Given this list of marker genes SNAI2, ATXN1L, MIR320B2, SOX17, RNF43, PTCH1 (patched 1), OVOL1, CD109, HMGB2, PIM1, HNRNPU, ZFP36L1, YAP1, TGFBR1, FGF8, MIR221, NF2, MIR320D1, NF1, ARIH2, AGO3, OVOL2, RUNX1, HMX2, VEGFC, MIR320D2, DSG2 (NCBI Gene Id 1829), IFT80, SHOX2, NFIB, NANOG, L3MBTL2, ETV6, PBX1, HOXB4, YTHDF2, CD34, ACE, RUNX2, SFRP2, FGF10, FGF4, CEBPA, KDM1A, PRRX1 (paired related homeobox 1), SHB, WNT10B, PDCD2, SIRT6, IRF6, MIR222, SOX18, WNT11, EIF2AK2, TP63, NR2E1, CITED1, CTNNB1, NKAP, BRCA2, NES, FGF2, RBPJ, MIR16-1, MIR93, RARG, MIR320C2, HOXA3, FBLN1, CCNE1, EPCAM, MIR320A, FGFR1, WNT1, WNT7B, WNT3, TP53, KDR, KAT7, KDF1, FGF9, TGFB1, XRCC5, BYSL (bystin like), GBA1, AXIN2, FERMT1, ELL3, LIG4, MIR320E, CTC1, MIR29B1, TGFBR2, SIX2 (NCBI Gene Id 10736), KITLG, THPO, MIR320C1, GJA1, GLI3, ZNRF3, TRIM71, TERT, TSC22D1 (TSC22 domain family member 1), WNT2B, DGCR8, BABAM1, MIR320B1, SFN, ANG, SHH, RARB, LTBP3, YJEFN3, PTPRC, WNT5A, NOTCH1, OSR2, TTYH1, SOX11, N4BP2L2, ERCC2, NDUFS6, MIR181A2, CDKN2C, MECOM, FERMT2, TBX3, SART3, HMGA2, SOX9, ABCB1, here is a description of the gene set: The multiplication or reproduction of stem cells, resulting in the expansion of a stem cell population. A stem cell is a cell that retains the ability to divide and proliferate throughout life to provide progenitor cells that can differentiate into specialized cells. Human Gene Set: GOBP_STEM_CELL_PROLIFERATION studied in species Homo sapiens